The following is a description of a gene set: studied in species Homo sapiens Genes down-regulated in T conv: peripheral lymph nodes versus thymic CD24 int. from publication Toker A, Engelbert D, Garg G, Polansky JK, Floess S, Miyao T, Baron U, Düber S, Geffers R, Giehr P, Schallenberg S, Kretschmer K, Olek S, Walter J, Weiss S, Hori S, Hamann A, Huehn J (PMID 23420886) Human Gene Set: GSE42021_TCONV_PLN_VS_CD24INT_TCONV_THYMUS_DN We investigated at which stage of maturation commitment to a stable Foxp3-expressing phenotype takes place. We assessed stability of Foxp3 expression in thymic Foxp3+ Treg subsets of different maturity, defined by CD24 expression. Next we compared gene expression profiles of Foxp3+ Treg subsets (+) of different maturity (24lo, 24int, 24hi) and could identify a set of genes that were specifically up or downregulated in Foxp3+ Tregs, but not in Foxp3- conventional T cells, in a maturation-dependent manner., and this is the list of marker genes: RNF10, SHISA5, IL9, IL13RA1, CYP7B1, KHDC1L, NMUR1, PHF23, SMNDC1, TCF7, ITK, CDCA3, LYL1, GGPS1, MST1R, CNN1, DAGLB, CAPN6, RPS15A, MEMO1 (mediator of cell motility 1), MRPL40, ITGA3, BRD2, AOC1, HMX1, OST4, CAPN3, HCN1, IGHM, POLE3, PRPF31, PDLIM1, MST1, ARGLU1, PCNT, MKI67, SREBF1, CPEB1, ESR1, UBD, RND2, ABHD17A, CD151, TINF2, PHETA1, SETDB1, LCN2, BLMH, NME6, SMPD2, KLF9 (KLF transcription factor 9), SLC3A2, ACTR3, BMI1, FOXC2, CHRNA6, BANF1, CD93, HIF1A, ESYT1, RIOK3, TPT1, TDRP, NUCKS1, TEAD1, EIF4A3, FBLN2, KCNJ9, FGF4, SOX10 (NCBI Gene Id 8223), COPS6, CBX6, ARHGDIB, ROS1, FOSB, EYA1, DCTN5, TIPARP, NPC1, OR4E2, ITCH, LOX, MRPS18B, KLRG1, F2RL2, RAB33B, IKZF2, NRGN, MEA1, ENTPD6, RPIA, VPS16, TRIM46, ANXA10, DNM1, LTF, RPS27, SGCG, GJC1, MYL11, RBM22 (NCBI Gene Id 55696), B3GALT1, LIFR, ADRA1A, SLC25A51, UBE2J2, RTL6, NBEAL2, C3orf38, TRIM11, OR13J1, RTN1, ACKR2, RAB3IL1 (NCBI Gene Id 5866), PARP6, ALDH1A1, S100A6, FGF13, SERPINA6, WNT3, HAT1, DTD2, MRPL14, YIPF3, HOXB9, MFSD1, IL27RA, ADGRB1, GLA, BOLA3, CYBA, KRT1, UPP2, GPAA1, ATP6V0C, KDELR2, XRCC5, GNAO1, TOMM40, TMEM68, SLC25A19 (solute carrier family 25 member 19), MUC13, BCL2L2, CFL1, ITSN1, SPNS1, INTS9, ELP3, PER3, PTPRK, DPP7, TPM3, GFI1, GHRH, IHH, UBA3, G6PD, ARL6IP1, C1orf174, UNC45A (unc-45 myosin chaperone A), ABCC5, P2RX7, RAD51AP1, EPHA6, NECAP1, UNC119B, TMEM38B, CLEC16A, ELANE, KLF4, PRKCZ, CBFB, AKIRIN2, POLR2A, COTL1, HOMER3, RGS14, IP6K1, ADA, NDUFB2, TCN2, CFTR (CF transmembrane conductance regulator), ODC1, BAG2, GRINA, BMP8B, HTR1D, B4GALT6, IGLC1, PLXND1, ACR (NCBI Gene Id 49), COPS7A, MYOD1, CBX4, SSTR2, ELOF1, ERG28, DLG1, TRPC5, AP5S1